The following is a description of a gene set: Human Gene Set: chr3q24 species: Homo sapiens, and this is the list of marker genes: PLSCR5-AS1, LINC02010, NPM1P28, LARP7P4, ZIC4, SLC9A9-AS1, RPL38P1, PLSCR2, RPL21P71, LINC02032, ST13P15, HLTF, HMGB1P30, ENSG00000305882, RPL21P39, RNU6-505P, LINC02045, UBQLN4P1, LNCSRLR, HNRNPA1P20, PLSCR1, HLTF-AS1, ZIC4-AS1, ENSG00000243620, AGTR1, MED28P2, CPA3 (carboxypeptidase A3), PBX2P1, LINC02046, HPS3, SLC9A9, CHST2, PLOD2, GM2AP1, CPB1 (NCBI Gene Id 1360), RNA5SP144, GAPDHP47, DIPK2A, PLSCR4 (NCBI Gene Id 57088), RPS17P10, GYG1, SLC9A9-AS2, UBTD2P1, PLSCR4P1, PLSCR5, ZIC1, RNU6-428P